The following is a description of a gene set: Mouse Gene Set: MIR_302C_5P species: Mus musculus from publication Chen Y, Wang X (PMID 31504780) Genes predicted to be targets of miRBase v22 microRNA mmu_miR_302c_5p in miRDB v6.0 with MirTarget v4 prediction scores > 80 (high confidence targets)., and this is the list of marker genes: Smarcad1, Rab31, Slc12a2, Tmem185b, Rab14, Zbtb14, Resf1, Atp6v1c1, 1700066M21Rik, Lman1, Zfp397, Rubcnl, Snurf, Cxcl2, Tmeff1, Braf, Ewsr1, Smad2 (SMAD family member 2), Gad1, Lrrn1, Cdk6, Zic3, Rrp1b, Pwwp2a, Exosc9, Etv1, Hcfc1r1, Tmed8, Ilk, Irs1, Rnf2, Fam169a, Gm12185, Pcsk5, Agfg1, Trmt1l, Ptprb, Tob1, Gabra4, Kdm7a, Ncl, Lrrtm2, Trabd2b, Tacr2, Msrb3, Tnrc6c (NCBI Gene Id 217351), Morf4l1, Selenoi, Spcs2, Cxcl13, Sel1l, Ccna2, Dnal1, Smad3, Dennd2d, Rapgef6, Eea1, Nbeal1, Rnf152, Otud7b, Atp2c1, Noa1, Dazap1, Hdac2 (histone deacetylase 2), Nfrkb (NCBI Gene Id 235134), Fcrla, Bicd1, Gbp3, Zfand5, Wnt3, Saxo2, Plagl2, Kif18a (kinesin family member 18A), Impg1, Trpc4ap, Gm12886, Rdh14, Ndfip2, Sema5b, Cd2ap, Dcaf12l2, Ppp1ca, Sox6, Nlk, Ap3s1, Fbxo45, Fmr1, Aebp2, Cnbp, Iqgap1, Actr8, Tbx22, Fbxw11, Srsf1, Itgb1, Ovol1, Chd1, Prrx1, Klhl2, 9930111J21Rik2, Ints2, Jmjd1c, Hcn1, Tial1, Pptc7, Hs2st1, Lrrc19, Gm715, Parp11, Coq2, Npat, Plxna2, Uri1, Tbx4, Arid4b, Dlst, Klra6, Clxn, Mef2a, Lclat1, Pak2, Med13 (mediator complex subunit 13), Slc9a6, Fam210a, Alcam, Bbs5, Epc2, Snrpn, Perp, Arpp19, Adgrf5, Satb1, Chst11, Gtf2h1, Zeb2, Smim13, Snrnp48, Grb2, Gtf2a1, Fut9 (NCBI Gene Id 14348), Cpne4, Pde5a, Ythdc2, Bmp15, Tfcp2, Pdcd4, Moxd1, Fndc3a, Krt12